The following is a description of a gene set: Mouse Gene Set: GOMF_MYOSIN_V_BINDING Binding to a class V myosin; myosin V is a dimeric molecule involved in intracellular transport. species: Mus musculus, and this is the list of marker genes: Rab3a, Rab27b, Rab3c, Npc1l1, Rab27a, Rab10, Fus, Gria1, Rab14, Rab11a, Taok1, Rab6b, Rab8a, Rab3d (NCBI Gene Id 83761), Rab11b, Rab6a, Mlph, Rab25, Rab3b, Rab39b